The following is a description of a gene set: Mouse Gene Set: WENG_POR_TARGETS_GLOBAL_UP from publication Weng Y, DiRusso CC, Reilly AA, Black PN, Ding X (PMID 16006652) Genes up-regulated in liver from transgenic mice with reduced expression of POR in all tissues. studied in species Mus musculus NADPH-cytochrome P450 reductase (CPR) is an essential component for the function of many enzymes, including microsomal cytochrome P450 (P450) monooxygenases and heme oxygenases. In liver-Cpr-null (with liver-specific Cpr deletion) and Cpr-low (with reduced CPR expression in all organs examined) mouse models, a reduced serum cholesterol level and an induction of hepatic P450s were observed, whereas hepatomegaly and fatty liver were only observed in the liver-Cpr-null model. Our goal was to identify hepatic gene expression changes related to these phenotypes. Cpr-lox mice (with a floxed Cpr gene and normal CPR expression) were used as the control. Through microarray analysis, we identified many genes that were differentially expressed among the three groups of mice. We also recognized the 12 gene ontology terms that contained the most significantly changed gene expression in at least one of the two mouse models. We further uncovered potential mechanisms, such as an increased activation of constitutive androstane receptor and a decreased activation of peroxisomal proliferator-activated receptor-alpha by precursors of cholesterol biosynthesis, that underlie common changes (e.g. induction of multiple P450s and suppression of genes for fatty acid metabolism) in response to CPR loss in the two mouse models. Additionally, we observed model-specific gene expression changes, such as the induction of a fatty-acid translocase (Cd36 antigen) and the suppression of carnitine O-palmitoyltransferase 1 (Cpt1a) and acyl-CoA synthetase long chain family member 1 (Acsl1), that are potentially responsible for the severe hepatic lipidosis and an altered fatty acid profile observed in liver-Cpr-null mice., and this is the list of marker genes: Cyp2c55, Hmgcs1, Gsta2, Scd1, Cyp7a1, Ethe1, Cyp2b10, Aqp8, Gck, Gstm2, Fdps, Cyb5b (NCBI Gene Id 66427), Dhcr7, Sqle, Gstm3, Idi1 (NCBI Gene Id 319554), Msmo1, Gstm6, Cyp51, Gsta3, Tcea3, Ces2c (NCBI Gene Id 234671)